Given this list of marker genes YWHAQ, AKT3, AKT1, BMF, YWHAE, YWHAZ, E2F1, PPP3R1, TP63, YWHAB, DYNLL2, BCL2, MAPK8, BCL2L11, PPP3CC, TFDP1, SFN, PMAIP1, DYNLL1, BID, AKT2, BBC3, YWHAG, YWHAH, TP73 (NCBI Gene Id 7161), PPP1R13B, TP53, TFDP2, BAD, TP53BP2, here is a description of the gene set: Activation of BH3-only proteins Human Gene Set: REACTOME_ACTIVATION_OF_BH3_ONLY_PROTEINS studied in species Homo sapiens